Given this list of marker genes Adcy3, Etnk1, Ifit3, Ube2v2, Slfn3, Cebpb, Ifngr2, Pcdhb21, St3gal4, Apex2, Mfsd1, Mepce, Ccl7, Ngp, Ccl5, Mx1, Grhl2, Oasl2, Col14a1, Yipf4, Patz1, Osmr, Lifr, Lrrc3b, Vdac1, Heatr1, Slfn2, Med28, Taf1a, Washc2, Parp3, Crem, Miga2, Prss23, Igtp, Slc25a44, Gm15246 (predicted gene 15246), Kpnb1, Abcc8, Atg10, Septin6, Oas3, Ifih1, Ptprt, Ebna1bp2, Trim8 (NCBI Gene Id 93679), Tasor2, Prrx1, Slc10a6, Bean1, Dtwd1, Gadd45a, Csf1, Ly75, Rcl1, Trim21, Erlin1, Rnf20, Ndufb2, Adi1, Rhbg, Erap1, Dnm3, Msl2, Tmem168, Ifi203, Rad52, Otof, Pnpt1, Ccar2, Col3a1, Egr1, Lmo4, Trip4, Rpe, Vwa5a, Retreg3, Tbxa2r, Etfrf1, H2-D1, Hnrnpab, Dus3l, Themis2, Tmem258 (NCBI Gene Id 69038), Bpnt1, Parp9, Itsn1, Mmp3, Cfb, Dlc1, Pthlh, Ap2b1, Tcim, Irf2, Synj2bp, Dffb, Max, Flcn, Pou3f4, Gbp4, Sirt4, C4b, Zfp36l1, Slfn8, Elp4, Capn6, Arfrp1, Pmepa1, Tead4, Mx2, Cdon, Ing3, Selenop, Gbp6, Ogn, Rev3l, Hoxb9, Tram2, Kcnj6 (NCBI Gene Id 547288), Slc2a3, Ifit2, Serf1, Kctd12, Fam210b, Ifi202b, Prelp, Alpl, Polr3d, Clec2h, Heatr6, Bst2, Tor3a, Tspan33, Reck, Sgk1, Col4a3, Gm20738, Trem3, Stk11ip, Jph1, Rnpc3, Cxcl1, Bcl6, Rfxank, Ptpn21, Atf4, Zfp672, Irf1 (NCBI Gene Id 16362), Gstm1, Hadh, Oas1b, Casq2, Efnb3, Clip1, Oxa1l, Spry1, Apol9a, Phldb2, Sp110, H2-T23, Slc24a3, Trim30d, Ccl9, Senp1, Arap2, Slc9a8, Ccnh, Klra3, Trp53inp1, Galc, Crb3, Sod2, Trafd1, Rrp12, Pcdhgb1, Tac4, Rims2, Rbmx, Bcan, Dpf3, Rbm43 (NCBI Gene Id 71684), Igfbp7, Uqcc4 (NCBI Gene Id 214489), Mccc2, Rpl30 (ribosomal protein L30), Trim30a, Rccd1 (RCC1 domain containing 1), Ifi204, Dync1li1, Clcf1, Ltbp2, Rev1, Eln, Cdk5r1, Fcgr4, Fbxw2, Wdr77, Shroom3, Slc29a2, Dbh, Sfxn2, Ppfibp2, Resf1 (NCBI Gene Id 77734), Mocs1, Irgm2, Fam216a, Tirap, Slc23a1, Col5a2, Daxx, Uba1y, Dnajc3, Riok2, Sptlc1, Cep112, Bgn, Slc35e4, Cp, Pcgf2, Uroc1, Bcl9, Stam2, Rpl35, Gbp2, Strap, Phip, BC023105, Atl3, Folr1, Iapp, Gm20815, Jak3, Rbbp9, Tmem140, Ino80e, Snrnp48, Saa1, Prss29, Ifit1, Uba7, Nxnl2, Hspa14, Trib2, Qtrt2, Saa3, Ccl2, Cxcl2, Zeb2, Etf1, Ssty2, Pfdn5, Abi3bp, Oasl1, Trp53, Slc18a1, Sema3b, Cxcl5, Tbca, Ifi35, Il18bp, Pik3c3, Elk1, Cdk5, Nnmt, Ints7, Rin2, Slc9b1, Dmp1, Plagl1, Fes, Oas1a, Alas1, Txndc16, Nedd9, Fsip1, Ehd2, Cxcl16, Cxcr5, Slc6a9, Ccn3, Tmed5, Dbt, Hoxb5, Rad1, Hspa8, Dimt1, Pdk4, Rnf32, Lgals3bp, Slc14a2, Ggta1, Hnf4a, Runx1, Osr1, Socs1, Fstl1, Tubb4b, Pdgfrb, Ddx25, Rabl3, Ube2i, Trim12a, Tgtp1, Tmpo (thymopoietin), Lox, Kalrn, Ccn2, Hspb1 (NCBI Gene Id 15507), Irgm1, Elovl4, Eif2ak2, Nacc2 (nucleus accumbens associated 2, BEN and BTB (POZ) domain containing), Klhl2, Tes3-ps, Gal3st1, Pes1, Sphk2, Kcna6, Aicda, Gm15834, Cebpd, Chac1, Ihh (Indian hedgehog), Col9a1, Txnrd3, Lamp3, Taf1d, Trmt10a (NCBI Gene Id 73171), Zfp65, Sycp3, Wfdc18, AY074887, Cyp21a1, Tprkb, Plp2, Dnajc27, Usp25, Ermap, Actb, Lztfl1, Fgfbp1, Isg15, Gm21943, Slc22a1 (solute carrier family 22 (organic cation transporter), member 1), Surf6, Myoc, Hsd11b1, Ivns1abp, Lrg1, Pde1b, Cd2, Igfbp4, Necab2, Bcr, Cmtm6, Shmt1, Gm20914, Cct4, Col5a3, Grin3b, Rcan3, Rps18, Lmnb1, Adar, Ndufaf4, Hipk2, Afg2a, Ifi27, Plpp3, Dusp6, Plk2, Prf1, Tmem167, Cntnap4, Casd1, Lipa, Zfp207, Dapk2, Gfra2, Pick1, Tmem268, Ifi47, Lrig1, Il1r1, Apobec1, Tceal1, Zfp738, Samhd1, Kcnmb2, Rtl6, Pth2, Ppid, Irf9, Cd59a, Prdx4, Zbp1, Fbn1, Usp13, Surf4, Donson, Helz2, Nmnat1, Zfp746, Gdf3, Tacr2, Pip5k1b, Fam118b, Tnfrsf22, Irs1, Pomk, Tbc1d1, Tor1aip1, Ypel1, Gm20747, Hhat, Utp11, Fndc3a, Pias1, Ubxn2b, Oas2, Pisd, Cntfr, Lypd8l, Tpbg, Vmn1r65, Wdr12, Mest, Ifi44, Xpr1, Slfn4 (schlafen 4, NCBI Gene Id 20558), Rrp15, Dcc, Tmem158, Cyp2c29, Wfdc21, Dcaf1, Abcc5, Hmbs, Vill, Gtf3c6, Txnip, Mir142hg, Nmd3, Gbp7, Steap4, Wdr4, Armc7, Zbtb32, Krt5, Npvf, Dnmt1, Pi4k2a, Sp100, Tlr3, C3, Boc, Pipox, Actl7b, Iigp1, Prdm1, Tmt1a, Galt, Exosc1, Plec, Neurog3, Hnrnpa1, Zfp503, Cdhr4, H2-T11-ps, Yipf5, Hoxb7, Mrpl57, Fjx1, Plekhf2, Trim25, Cdca3, Tlr2, Cul4a (NCBI Gene Id 99375), Lgals12, Lig3, Marchf5, Ifi211, Septin7, Angpt1, Cebpg, Casp7, Irf7, Cxcl10, Cnih2, Efnb1, Inhbb, Trim34a, Psmb10, Pnp, Tm4sf1, 5730488B01Rik, Ptger4, Aqp1, Lce1a2, Ints8, Apmap, Cip2a, Myd88, Cyp1a1, Tyw1, Ern1, Clps, Apol9b, Sox4, Pde7a, Dkk3, Ctps1, Plscr1, Ccser2, Smr2, Gca, Dst, Rsad2, Cldn3, Gpaa1, Mesp1 (NCBI Gene Id 17292), Ncl, Kifc2, Gm5644, Cmpk2, Nop58, Arhgap39, Stat2, Zfp931, Pdhb, Skic8 (SKI8 subunit of superkiller complex), Fhip1b, Cacna1a, Trub2, Ccnc, Ccn5, Phlda2, Rnf144b, Acot6, Avpr1a, Kng1, Adamts10, Nck1, Crhr1, Ikbkb, Uri1, Nifk, Xdh, Ifnar2, N4bp2l1, Asz1, Pla2g2e, Cyp4f13, Nkx2-3, Wdr75, Ppp1r10, Pcdhb17, Cyp2b19, Ighg1, Gadd45b, Chchd5, Osgin2, Mtfp1, Usp18, Hoxb8, Rnd3, Pcdhb22, H3c14, Hsd11b2 (NCBI Gene Id 15484), Aatf, Tap2, Hmga2, Enc1, Adcy7, Cimip3, Myc, Ahr, Egf, a, Stat1, Bcl2l2, Ptpn14, C030006K11Rik, Efnb2, Vapa, Ppif, Ghr, Rho, Htatsf1, Parp12, Slc39a4, Sprr1a, Smyd5, Coro1c, Becn1, Rtp4, Wnt7b, Rest, Parp14, Uba52, Grhl1, Mmd, Gm20934, Ddx60, Fas, Aen, Alg13, Hmgcr, Arl14ep, Gm5530, Kdf1, Tifa, here is a description of the gene set: Genes up-regulated in ME-A cells (breast cancer) undergoing apoptosis upon serum starvation (5% to 0% FCS) for 22 hr. studied in species Mus musculus Impairment of the complex regulatory network of cell death and survival is frequently the reason for therapy resistance of breast cancer cells and a major cause of tumor progression. We established two independent cell lines from a fast growing mouse breast tumor (WAP-SVT/t transgenic animal). Cells from one line (ME-A cells) are sensitive to apoptotic stimuli such as growth factor depletion or treatment with antitumor agents (e.g. doxorubicin). Cells from the second line (ME-C cells), which carry a missense mutation at the p53 codon 242, are very insensitive to apoptotic stimuli. Co-cultivation experiments revealed that the ME-C cells mediate cell death resistance to the ME-A cells. Microarray and Western blot analysis showed that osteopontin (OPN) is selectively overexpressed by the ME-C cells. This glycoprotein is the most abundant protein secreted by the ME-C cells and we obtained strong indications that OPN is the main antiapoptotic factor. However, the OPN containing ME-C cell medium does not alter the expression level of pro- or antiapoptotic genes or known inhibitors of apoptosis (IAPs). Its signaling involves mitogen-activated protein kinase (MAPK)/extracellular signal-regulated kinase (ERK) kinase (MEK)1/2 as the kinase inhibitor PD98059 restores apoptosis but not the Akt inhibitor. In the ME-A cells, mitochondrial cytochrome c release occurs with and without external apoptotic stimuli. OPN containing ME-C cell medium does not prevent the mitochondrial cytochrome c release and caspase-9 processing. In serum starved ME-A cells, the OPN containing ME-C cell medium prevents caspase-3 activation. However, in doxorubicin-treated cells, although apoptosis is blocked, it does not inhibit caspase-3. This indicates that the ME-A cells distinguish between the initial apoptotic stimuli and that the cells possess a further uncharacterized control element acting downstream from caspase-3. from publication Graessmann M, Berg B, Fuchs B, Klein A, Graessmann A (PMID 17160024) Mouse Gene Set: GRAESSMANN_APOPTOSIS_BY_SERUM_DEPRIVATION_UP